The following is a description of a gene set: T cell anergy is one of the mechanisms contributing to peripheral tolerance, particularly in the context of progressively growing tumors and in tolerogenic treatments promoting allograft acceptance. We recently reported that early growth response gene 2 (Egr2) is a critical transcription factor for the induction of anergy in vitro and in vivo, which was identified based on its ability to regulate the expression of inhibitory signaling molecules diacylglycerol kinase (DGK)-a and -z. We reasoned that other transcriptional targets of Egr2 might encode additional factors important for T cell anergy and immune regulation. Thus, we conducted two sets of genome-wide screens: gene expression profiling of wild type versus Egr2-deleted T cells treated under anergizing conditions, and a ChIP-Seq analysis to identify genes that bind Egr2 in anergic cells. Merging of these data sets revealed 49 targets that are directly regulated by Egr2. Among these are inhibitory signaling molecules previously reported to contribute to T cell anergy, but unexpectedly, also cell surface molecules and secreted factors, including lymphocyte-activation gene 3 (Lag3), Class-I-MHC-restricted T cell associated molecule (Crtam), Semaphorin 7A (Sema7A), and chemokine CCL1. These observations suggest that anergic T cells might not simply be functionally inert, and may have additional functional properties oriented towards other cellular components of the immune system. from publication Zheng Y, Zha Y, Spaapen RM, Mathew R, Barr K, Bendelac A, Gajewski TF (PMID 23548837) Human Gene Set: GSE46242_TH1_VS_ANERGIC_TH1_CD4_TCELL_WITH_EGR2_DELETED_DN species: Homo sapiens Genes down-regulated in CD4 Th1 cells with EGR2 knockout: control versus anergic., and this is the list of marker genes: ZRSR2, ZNF383, GLYATL2, ME3, PIGS, SCCPDH, MIR99AHG, HGSNAT, KLF11, BAHD1, CEP164, NUP214, CSTL1, CALHM2, PRM3, RNASE4, KLHL18, ACTN4, AKT1, PAQR4, GPT, STK17B, GCN1, MVP, UBE2G2, ACTG1, STAT3, OAS1, HHIP, CD47, ANXA5, NDUFA4, FAM162B, SEPTIN9, VCL, HADH, GLIPR2, FOXP1, DNAJA1, BMP8B, EXD3, FOXA3, IGFBP7, AMIGO2, RFXAP (regulatory factor X associated protein), CMTM8, ADAMTS15, FAM241B, RARA, CMPK2, ENSG00000289161, CAP1, SLC38A10, CIBAR1, SMARCC2, RHOU (NCBI Gene Id 58480), ADRB2, FAR2P2, CDYL, PTX3, OPN3, ZNF790-AS1, SNX1, AATBC, RTN4, OR5AK4P, MRPL34, LZTS1, TTC39B, SCEL, FCHO1, FKBP5 (NCBI Gene Id 2289), ZNF625, DAG1, DYNC1LI1, SNTG2, SHC1 (NCBI Gene Id 6464), ANAPC15 (NCBI Gene Id 25906), COX14, IRS4, HNRNPA2B1, ABHD4, KLHDC3, TAF5LP1, EXD2, SLC39A6, METTL9, PECR, UBALD1 (UBA like domain containing 1), LINC01089, PLIN2, HERC5, TEX101, TIPARP (TCDD inducible poly(ADP-ribose) polymerase), NUCB1, SCARB1, C20orf173, ABCG2, SLC25A26, EGR2, PLSCR2, ALDOA, UBB, CAPRIN2, MAP4K1, TAFA4, IL7R, IKBKG, S1PR4, ALKBH5, LPCAT3, PRCP, STARD7, MEGF9, SECTM1, UNC119, TMEM223, DOCK11, S100A5, CA4, ATP11B, PITPNC1, SLC35A1, ADORA2B, AGPAT2, SH2B2, DNM1P46, SLAMF9, C1orf162, CCDC88C, DDIAS, SLC35E4, ST6GALNAC2, C18orf21, TMC6, AGGF1, SLC25A1, GGA2, AQP3, POLL, OR2W3, GPRC5D-AS1, CALCOCO2, PODXL, CEP112, GPD1L, RGS3, GPR146, ADH1A, TYW3 (tRNA-yW synthesizing protein 3 homolog), SBNO2, ETFA, LPCAT4, CATSPER3, AAMDC, ZNF232, PCOLCE2, POU5F1P3, INF2, PIP4K2A, IL1R2, ZC3H14, KCTD6 (NCBI Gene Id 200845), STAT6, TRPV2, EGLN2, STAC, OR2A4 (NCBI Gene Id 79541), RAMP1, NMB, WDFY4, IFFO2, SEMA4D, NPR2, TCERG1L, TUSC2, ANKRD13A, DOK2, PGP, EHD4, CTTNBP2, TMEM200B, NKX3-2, TMEM125, SLC25A46, GNAQ, CIC, DGKZ, PTGFR, SEPTIN10, PRL, CHST12, PREX2